The following is a description of a gene set: from publication Chen Y, Wang X (PMID 31504780) Genes predicted to be targets of miRBase v22 microRNA mmu_miR_1970c_5p in miRDB v6.0 with MirTarget v4 prediction scores > 80 (high confidence targets). studied in species Mus musculus Mouse Gene Set: MIR_1970C_5P, and this is the list of marker genes: Swt1, Cxcr6, Katnal1, Prkce, Lef1, Prelid3a, Hkdc1, Ticam1, Ift57, Tead1, Cdk14, Trim30d, Adam22, Or51ab3, Peds1, Heg1, Sap130, Crisp3, Tlr2, Tgds, Zc3h12c, Prnd, Camk2d (NCBI Gene Id 77170), Cartpt, Abca1, Shisa9, Fam120b (NCBI Gene Id 67544), Fosl2, Cers4, Ppfibp1, Sntg1 (syntrophin, gamma 1), Oas1g, Cts3, Thra, Fut8, Zfp750, Gnrhr, Scamp1, Prn, Hspa5, Plekha8, Xpo7, Mroh1, Phka2, Jdp2, Tpmt, Ankfy1, Rimklb, Hycc2, Bod1l, Srsf3, Phip, Larp4, Siglece, Trim32, Zc3h12d, Prkab2, Tada2b, Mat2b, G3bp2, Prox1, Zfp9, Ube2q2, Ddx6, Cep135, Cideb, Cfap418, Foxk2, Tpr, Trpm1, Cacna1h, Rnf150, Ccdc178, Edrf1, Grk3, Scn2a, Xrcc4, Pnpla2, Sgk1, Usp24 (ubiquitin specific peptidase 24, NCBI Gene Id 97161), Pwwp2a, Prkag2, Ano4, Crisp1, Tlx1 (T cell leukemia, homeobox 1), Arhgap42, Ddx47, Lin28a, Smim33, Ctbp2, Nfatc2, Vegfb, Bccip